The following is a description of a gene set: species: Mus musculus Binds to and decreases the activity of an enzyme that catalyzes a ring closure reaction. Mouse Gene Set: GOMF_CYCLASE_INHIBITOR_ACTIVITY, and this is the list of marker genes: Nherf4, Gnaz, Grm7, Gnai1, Adgrv1, Rgs2